The following is a description of a gene set: Genes predicted to be targets of miRBase v22 microRNA mmu_miR_1931 in miRDB v6.0 with MirTarget v4 prediction scores > 80 (high confidence targets). Mouse Gene Set: MIR_1931 species: Mus musculus from publication Chen Y, Wang X (PMID 31504780), and this is the list of marker genes: Foxg1, Tcea1, Draxin, Wfdc8, Tle1, Slc9a6, Igf1, Sema6a, Ccm2l, Ddx4, Scgb1b12, Zfp275, Myrip, Rab3c, Rnf122, Abhd5, Fmr1, Tmem248, Kif26b, Ebf1, Cpeb1, Scgb1b20, Hspa12a, Ctps1, Zfp28, Sos1, Mapkap1, Scamp5, Kdm2b, Rps6kb1, Sim1, 9330159F19Rik (NCBI Gene Id 628860), Sik1, Scgb1b29, Oprm1, Stag2, Tjp1 (tight junction protein 1), Entrep1, Qki, Vat1l, Gm5622, Usp37, Ro60, Negr1, Bicd2, Dyrk3, Ankrd44, Eif2s2, Akr1b1, Scgb1b7, Dcbld1, Ahcyl1, B230219D22Rik, Gfra2, Tmprss11a, Abhd16b, Cacnb4, Oser1 (NCBI Gene Id 66680), Coil, Dsel, Map3k9